Given this list of marker genes MIR195, AKT2, PPP1R3B, PPP1R3F, PASK, GCK, RUBCNL, PTH (parathyroid hormone), IRS2, GCGR, POMC, ADCY10, PPP1CA, PHLDA2, PRKAG3, PHKA1, SORBS1, PPP1R3D, SELENOS, KHK, INS, PPP1R3C (protein phosphatase 1 regulatory subunit 3C), GRB10, MIR1271, IGF2, PHKG2, HMGB1 (high mobility group box 1), PPP1R3G, IGF1, ENPP1, EPM2AIP1, GSK3B, PPP1R3E, MIR15B, AKT1, GSK3A, INPP5K, PPP1R3A, DYRK2, IRS1, INSR, here is a description of the gene set: Any process that modulates the frequency, rate or extent of the chemical reactions and pathways involving glycogen. Human Gene Set: GOBP_REGULATION_OF_GLYCOGEN_METABOLIC_PROCESS studied in species Homo sapiens